Given this list of marker genes NUP98 (NCBI Gene Id 51457), NUP133, NUP210, NUP205, RANBP2, NUP88, NUP43, NUP160, RANGAP1, RAN, NUP58, TPR, NDC1, NUP50, RANBP1, NUP153, RCC1, RAE1, NUP85, NUP155, SEC13, POM121C, NUP62, NUP107, SEH1L, NUP37, NUP93, NUP214, XPO1, AAAS, POM121, NUP42, rev, NUP35 (NCBI Gene Id 129401), NUP54, NUP188, here is a description of the gene set: The HIV-1 genome contains genes encoded by a single transcript. In order for the virus to replicate, unspliced, singly-spliced and fully spliced viral mRNA must be exported from the nucleus. The HIV-1 mRNA splice sites are inefficient resulting it the accumulation of a pool of incompletely spliced RNAs. In the early stages of the viral life cycle, or in the absence of the viral Rev protein, completely spliced viral mRNA which encode the regulatory proteins Tat, Nef and Rev are exported from the nucleus while the incompletely spliced structural protein encoding transcripts are held within the nucleus by cellular proteins that normally function in preventing the nuclear export of cellular pre-mRNA. Export of both unspliced and partially spliced mRNA is mediated by the viral protein Rev which is recruited, along with cellular cofactors, to the Rev Response Element (RRE) within the HIV-1 mRNA sequence. The cellular hRIP protein is essential for correct Rev-mediated export of viral RNAs to the cytoplasm. studied in species Homo sapiens Reactome Pathway: Rev-mediated nuclear export of HIV RNA part of: Interactions of Rev with host cellular proteins; Late Phase of HIV Life Cycle